The following is a description of a gene set: Mouse Gene Set: GOCC_PRERIBOSOME Any complex of pre-rRNAs, ribosomal proteins, and associated proteins formed during ribosome biogenesis. species: Mus musculus, and this is the list of marker genes: Riok2, Pwp2, Nop14, Rps16, Rps4x, Wdr12 (NCBI Gene Id 80478), Rps19bp1 (NCBI Gene Id 66538), Xrcc5, Rps5, Rrs1, Rcl1, Fbl, Nop56, Pno1 (NCBI Gene Id 66249), Utp15, Utp4 (NCBI Gene Id 21771), Ltv1, Wdr75, Pdcd11, Dcaf13, Dnttip2, Riox1, Heatr1, Wdr3, Mrto4, Exosc10, Dimt1, Utp11, Nol6, Rrp7a, Rps19, Mak16, Rrp1b, Nop58, Rps3a1 (ribosomal protein S3A1), Noc2l, Rps27 (ribosomal protein S27), Imp3, Rps7, Ftsj3, Utp20, Mdn1, Noc4l, Utp14b, Nop9, Rps6-ps4, Riok1, Casp8, Imp4, Bms1, Wdr46, Rps15a, Nob1, Rps24, Rps23 (ribosomal protein S23), Rps6, Slx9, Aatf, Rps12, Utp23, Nat10, Rrp1, Zfp622, Tbl3, Rpf1, Utp14a, Pes1, Utp3, Rps13, Nol7, Pin4, Rps11, Wdr43, Ppan, Rps27a, Utp6, Rps28, 2810004N23Rik (NCBI Gene Id 97436), Snu13, Nol10 (NCBI Gene Id 217431), Utp25, Prkdc, Bysl, Rrp15, Dhx37, Wdr74, Mphosph10, Rrp36, Nip7, Srfbp1, Fcf1, Krr1, Rps8, Rps9, Emg1, Rps17, Utp18, Riok3, Kri1, Ngdn, Fbll1, Nsa2, Bop1, Wdr36, Rrp9, Rps14, Rps27rt, Ebna1bp2